Given this list of marker genes HLA-G, HLA-F, HLA-DRA, CD74, ULBP3, ATG5, HLA-A, ULBP1, HLA-B, CD1A, IDE, CD1C, RAET1E, TAP1 (transporter 1, ATP binding cassette subfamily B member), ULBP2, AZGP1, CD1B, CD1D (NCBI Gene Id 912), HLA-E, RAET1G, TAPBP, HLA-C, TAP2, RAET1L, B2M, ERAP1, HFE, ERAP2, HLA-DRB1, HLA-H, CD1E, here is a description of the gene set: species: Homo sapiens The process in which an antigen-presenting cell expresses antigen (peptide or lipid) of endogenous origin on its cell surface in association with an MHC protein complex. Human Gene Set: GOBP_ANTIGEN_PROCESSING_AND_PRESENTATION_OF_ENDOGENOUS_ANTIGEN